Given this list of marker genes CYP17A1, F13B (coagulation factor XIII B chain), HSD17B4, HSD3B1, HSD3B2, HSD17B2, HSD17B7, HSD17B1, CPN1, HSD17B3, here is a description of the gene set: Steroid biosynthesis Human Gene Set: WP_STEROID_BIOSYNTHESIS species: Homo sapiens